The following is a description of a gene set: from publication Chen Y, Wang X (PMID 31504780) Human Gene Set: MIR3168 species: Homo sapiens Genes predicted to be targets of miRBase v22 microRNA hsa-miR-3168 in miRDB v6.0 with MirTarget v4 prediction scores > 80 (high confidence targets)., and this is the list of marker genes: SLAIN2, POTEA, COBLL1, ARHGAP6, MEIOC, ARID4A, ALG10B, SCML1, ZNF644, CCDC91, NTN1, DPY19L1, FBXO39, ITGA8, SLC38A1, KAT6A, ATXN1L, FCRL1, ZBTB46, DIP2C, TTC28, HYCC2, KIF23, ANKRD28, SP4, ARMC3, MCCC2, LAMTOR5 (NCBI Gene Id 10542), TMED4, ZNG1A, MBNL1, BMPR2, ERICH2, HDAC2, HNMT, GIPC3, MGA, TRA2B, MXRA7, PHF11, SEL1L, LMO1, BRWD1 (bromodomain and WD repeat domain containing 1), TSPAN2, NR2C1, ZEB2, RAP1GDS1, RCHY1, TRIM34, UNC5C, ZKSCAN3 (NCBI Gene Id 95379), CFAP97, NFAT5, BMPR1A, CELF3, DUSP6, UBR3, SLC39A9, ALAD, ZNF236, SGO1, NECAB1, YBX1, TMED5 (NCBI Gene Id 50999), ACAP2, PAPOLA, IQCB1 (NCBI Gene Id 9657), PCYT1A, ZNF345, OXTR, ZMYM2, CA8, G3BP2, TOR1AIP2, SLC11A2, TMEM106B, NF1, PLEKHA1, USP50, BNIP2, ID4, B4GALT6, SLC9A4, SLC7A11, FOXO3, TAFA1, CROT, FAM117B, PON2 (NCBI Gene Id 5445), ZDHHC21, MEGF10, RASEF, ORC2, TRIM6-TRIM34, PROX1, ARID2, RORA, SPA17, CLCC1, MBLAC2, PIK3C2A, RGS2, PCYOX1, GK5, WIPF2, ZNF550 (NCBI Gene Id 162972), LZTFL1, KATNBL1, MBD2, RNF41, TARDBP, ZBTB10, VAPB, DNAJC6, CFAP52, NFIA, ZNG1C, MCTP1, SKI, ZNF362, MACROH2A2, MMP16 (NCBI Gene Id 84257), ZMAT3, RNFT1, LPCAT2, SPMIP4, MEMO1, CBLN2, TXLNG, TAGLN3, MDH1B, DYNC1I2, FAM169A